The following is a description of a gene set: species: Homo sapiens Human Gene Set: HP_HYPOPLASIA_OF_OLFACTORY_TRACT Hypoplasia of olfactory tract, and this is the list of marker genes: OFD1, PDE6D, TOPORS, KIAA0753, TMEM216, SOX9, CPLANE1, KIF7, FAM149B1, TMEM231, TCTN3